The following is a description of a gene set: Mouse Gene Set: GOBP_REGULATION_OF_CAMKK_AMPK_SIGNALING_CASCADE studied in species Mus musculus Any process that modulates the frequency, rate or extent of CAMKK-AMPK signaling cascade., and this is the list of marker genes: Trem2 (triggering receptor expressed on myeloid cells 2), Lrrk2, Sco1, Htt, Egln1, Myh7b, Pcp4